The following is a description of a gene set: species: Mus musculus This event has been computationally inferred from an event that has been demonstrated in another species.<p>The inference is based on the homology mapping from PANTHER. Briefly, reactions for which all involved PhysicalEntities (in input, output and catalyst) have a mapped orthologue/paralogue (for complexes at least 75% of components must have a mapping) are inferred to the other species. electronically inferred by orthology from the curated human pathway Reactome Pathway: Apoptosis part of: Programmed Cell Death, and this is the list of marker genes: Aven, Ly96, Oma1, Fas, Casp7, Gas2, Dffa, Casp3, Add1, Fadd, Casp9, Lmnb1, Dynll1, Bcap31, Dsg3, Vim, Ocln, Dsg1a, Mapk8, Casp8, Ywhah, Bcl2l1, Gsdmd, Nmt1, Hmgb2, Sfn, Mapk3, Lmna, Septin4, Ywhae, Ptk2, Dffb, Gzmb (granzyme B), Cdh1, Tlr4, Fnta, Kpna1, Casp6, Cycs, Fasl, H1f3, Kpnb1, Opa1, Cd14, Apip, H1f4, Gsn, Ppp3cc, Dnm1l, Bax, Tradd, Hmgb1, Sh3glb2, Stk26, Ppp3r1, H1f1, Ticam2, Mapt (NCBI Gene Id 17762), Bak1, Pmaip1, Bad, Ctnnb1, H1f5